Given this list of marker genes JAM2, CRISPLD1, TENM3, SPINT2, DPT, EYA2, S100A4, CTSK, CHL1, INHBA, HMGCLL1, HAPLN3, FNDC1 (fibronectin type III domain containing 1), TM4SF1, MXRA5, PCK2, GPR180, FIBIN, RBP4, AR, MME, SPOCK3, CYP1B1, PEG3, COL2A1, ANOS1, EFEMP1, F2RL2, SCGB3A2, S100B, ZEB1 (zinc finger E-box binding homeobox 1), COL9A3, NPPC, SIX1, PDGFC (NCBI Gene Id 56034), GFPT2, KCNE5, MPPED2, FOXC1, PDPN, CPM, SERPINF1, PDGFRL, FBN2, LDB2, MECOM, THSD4, PRRX1, SERTAD4, COL12A1, KDELR3, FRZB, THBS3, OMD, ITM2A, CTHRC1, COL11A1, MATN4 (matrilin 4), HAPLN1, THBS2, EGLN2, FST, SOX6, ERG, SERTAD4-AS1 (SERTAD4 antisense RNA 1), FGFR2, RFLNA, UCMA, TWIST2, TMEM100, NTRK2, CILP2, PDGFD, COL15A1, EYA4, YPEL2, DLK1, CNMD, ASPN, LRRN1, BOC, PLP2, WWP2, COL9A1, PI15, COL8A1 (NCBI Gene Id 57086), MPZL2, FLI1, ARPC1B, AIF1, RHOD, IQGAP2, RARG, NRK (Nik related kinase), STEAP1, EMILIN3, CAPN6, RTKN, COL9A2, CAPG, SOX9, PROM1, CDC42EP3, STEAP2, CFH, TSPAN13, SMOC1, COL8A2, AUTS2, MIA, ACAN, COL25A1, KCTD1, TTYH1, LMO7, TWIST1, NPDC1, here is a description of the gene set: species: Homo sapiens from publication He P, Lim K, Sun D, Pett JP, Jeng Q, Polanski K, Dong Z, Bolt L, Richardson L, Mamanova L, Dabrowska M, Wilbrey-Clark A, Madissoon E, Tuong ZK, Dann E, Suo C, Goh I, Yoshida M, Nikolić MZ, Janes SM, He X, Barker RA, Teichmann SA, Marioni JC, Meyer KB, Rawlins EL (PMID 36493756) Human Gene Set: HE_LIM_SUN_FETAL_LUNG_C0_ASPN_POS_CHONDROCYTE ASPN+ chondrocyte